Given this list of marker genes C8G, C6, C8A, C9, C8B, C5, C7, CLU, here is a description of the gene set: Reactome Pathway: Terminal pathway of complement species: Homo sapiens After cleavage of C5, C5b undergoes conformational changes and exposes a binding site for C6. C5b6 binds C7 resulting in the exposure of membrane binding sites and incorporation into target membranes. The membrane-bound C5b-7 complex can then bind C8. C5b-8 acts as a polymerizing agent for C9. The first C9 bound to C5b-8 undergoes major structural changes enabling formation of an elongated molecule and allows binding of additional C9 molecules and insertion of C9 cylinders into the target membrane. The number of C9 molecules varies from 1-12 in the membrane, although polymers containing up to fifteen C9 molecules are also possible. part of: Complement cascade